The following is a description of a gene set: Human Gene Set: GOBP_MRNA_5_SPLICE_SITE_RECOGNITION Recognition of the intron 5'-splice site by components of the assembling spliceosome. species: Homo sapiens, and this is the list of marker genes: SRSF12 (serine and arginine rich splicing factor 12), RNVU1-3, RNVU1-4, RNVU1-14, SNRPC, WEE2-AS1, RNU4ATAC, RNU1-4, RNVU1-15, RNVU1-19, RNVU1-7, TAF12-DT, PSIP1, RNVU1-1, RNVU1-2A, RNU6ATAC, RNU11, RNVU1-17, SFSWAP, RNVU1-8, PRPF39, RNVU1-6, SRSF1 (serine and arginine rich splicing factor 1)